Given this list of marker genes MRPS2, ELAC2, CPEB2, SNX15, KDELR2, EIF3L, IFRD2, CENPB, SMARCC1, FICD, MCUB, SPRYD4 (SPRY domain containing 4), STAG1, DDX56, LONP1, CDKN2B, ARL3, KCNA3, WDR13, CCDC71L, ELP1, PDCL, STT3A, RAB11A, ABL1, GPC1, PAPSS1, DARS1, MSANTD4, SEC31A (NCBI Gene Id 51424), NUDCD1, B4GALT7, SNRPD2, CLPP, GMFG, SOD2, EIF1AX, SIMC1, OAT, EIF3A, SRRT, ZNF330 (zinc finger protein 330), OTOG, SNRPA, TRAPPC1, LIPT2, PDF, CKS2, PATZ1, ABRACL, OSBPL2, MRM3, SRP9, CMYA5, TP53BP1, TTC39C, PPP3CC, LMAN1 (NCBI Gene Id 3998), CDON, ZBTB22, SLC12A4, DCAF1, NELFB, JAK1, CARM1, COX19, LRRC49, NOP56, SASH1, TIMM8A, JADE1, ZNF287, DDX24, RPAP2, CYP51A1, PLEKHA7, RETREG2, DPH5, SYNCRIP, PPP2CB, SLC41A1, PPT2, ZNF600, PSMB7, KPNA1, GGH, C18orf32, GSTM1, RXYLT1, VPS29 (VPS29 retromer complex component), SMIM30, TPRG1L, HNRNPK, POLA2, ENTR1, TGM2, SAE1, NELFE, TNFRSF21, LRPAP1, UBP1, DHX36, MRPL23, RABGGTB, SLK, NOP10, TRMT112, FKBP1A, KIAA0319L, TTI1, CDK2AP1, POLR2B, DHCR24, PROCR, UBE2M, BCCIP, NME6, ANKRD40, DHX15, CTBP1, CCDC117, NOSIP, LUC7L, C2orf49, SUGP2, MTFR1L, CLPB, SP3, GPR85, MSANTD3, CNIH1 (NCBI Gene Id 10175), ACTN4, PAGR1, LAD1, CHAC2, EFNA2, RPS6, CAB39L, RTCB, INTS7, ZNF362, SORCS1, CCDC47, PRKCB, F10, NOMO1, KICS2, NCBP1 (NCBI Gene Id 4686), IMPDH2, EIF4E, SPAG7, TBRG4, UXT, NCSTN, IFITM10, SLC52A2, FSCN3, SLC35A4, C11orf24, NHP2, ETFRF1, TESK1, INHBA, RAB18, IGF2BP1, HERPUD1 (homocysteine inducible ER protein with ubiquitin like domain 1), ATP6V1G2, MGAT2, BEST2, IER2, GSS, RPL5, P2RY6, MSN, NUDT16, TNC, PYY, UBQLN1, DGAT1, KIF13A, POMP, HERC2, HYOU1, HPF1, ACAT2 (NCBI Gene Id 39), SNRPD1, FBF1, CFL2, PLAUR, CUL1, SOCS4, ELOVL1, PRMT5, NAGK, GFER, OPN3, FAM118A, PABIR1, MPHOSPH10, ORMDL2, here is a description of the gene set: from publication Amit I, Garber M, Chevrier N, Leite AP, Donner Y, Eisenhaure T, Guttman M, Grenier JK, Li W, Zuk O, Schubert LA, Birditt B, Shay T, Goren A, Zhang X, Smith Z, Deering R, McDonald RC, Cabili M, Bernstein BE, Rinn JL, Meissner A, Root DE, Hacohen N, Regev A (PMID 19729616) Human Gene Set: GSE17721_POLYIC_VS_GARDIQUIMOD_8H_BMDC_DN mouse primary BMDCs were stimulated with tlr ligands and gene expression changes were profiled on Affymetrix arrays species: Homo sapiens Genes down-regulated in comparison of dendritic cells (DC) stimulated with poly(I:C) (TLR3 agonist) at 8 h versus DC cells stimulated with Gardiquimod (TLR7 agonist) at 8 h.